Given this list of marker genes MMAA, MMUT, here is a description of the gene set: Defects in MMAA cause methylmalonic aciduria type cblA (cblA aka methylmalonic aciduria type A or vitamin B12-responsive methylmalonic aciduria of cblA complementation type; MIM:251100). Affected individuals accumulate methylmalonic acid in the blood and urine and are prone to potentially life threatening acidotic crises in infancy or early childhood. part of: Defects in cobalamin (B12) metabolism studied in species Homo sapiens Reactome Pathway: Defective MMAA causes MMA, cblA type